Given this list of marker genes LGALS3, AFP, BTG2, CYBB, COL4A1, EGR1, TGFBR2, STAT1, TGFB1, UCP2, VCAM1, COL4A2, FGFR2, SPARC, FOS, LAPTM5 (NCBI Gene Id 7805), CDKN1A, BEX1, HBEGF, ITGAL, SPP1, CDKN2B (NCBI Gene Id 1030), COL1A1, CASP1, TGM2, APP, COL1A2, KRT18, RAI14, H19, SERPINE1, LGALS1, PDGFA (platelet derived growth factor subunit A), ICAM1, EMP1, RBP1, CD38, ITGAV, TP53, IGF2 (insulin like growth factor 2), HCK, JUNB, VIM, CP, SAMD4A, CD44, CDH1, here is a description of the gene set: Human Gene Set: KHETCHOUMIAN_TRIM24_TARGETS_UP from publication Khetchoumian K, Teletin M, Tisserand J, Mark M, Herquel B, Ignat M, Zucman-Rossi J, Cammas F, Lerouge T, Thibault C, Metzger D, Chambon P, Losson R (PMID 18026104) studied in species Mus musculus Retinoic acid-responsive genes up-regulated in hepatocellular carcinoma (HCC) samples of TRIM24 knockout mice. Hepatocellular carcinoma (HCC) is a major cause of death worldwide. Here, we provide evidence that the ligand-dependent nuclear receptor co-regulator Trim24 (also known as Tif1alpha) functions in mice as a liver-specific tumor suppressor. In Trim24-null mice, hepatocytes fail to execute proper cell cycle withdrawal during the neonatal-to-adult transition and continue to cycle in adult livers, becoming prone to a continuum of cellular alterations that progress toward metastatic HCC. Using pharmacological approaches, we show that inhibition of retinoic acid signaling markedly reduces hepatocyte proliferation in Trim24-/- mice. We further show that deletion of a single retinoic acid receptor alpha (Rara) allele in a Trim24-null background suppresses HCC development and restores wild-type expression of retinoic acid-responsive genes in the liver, thus demonstrating that in this genetic background Rara expresses an oncogenic activity correlating with a dysregulation of the retinoic acid signaling pathway. Our results not only provide genetic evidence that Trim24 and Rara co-regulate hepatocarcinogenesis in an antagonistic manner but also suggest that aberrant activation of Rara is deleterious to liver homeostasis.